Given this list of marker genes ABO, GATAD1, CXCR4, HBBP1, TRIP10, ERVW-1, SEMA7A, LPAR4, KIF25-AS1, SERPING1, INA, ALOX15B, SEMA4D, PRPF3, OBSL1, STAR, MPZL1, RALGAPB, MAG, AK1, APOL1, CECR7, CHAF1B, DEFB1, ST3GAL1, SAT1, TNFAIP3, KLF7, CYB5A, PITPNM1, USP20, CCNA2, FAM110B, KALRN, LBP, STX11 (syntaxin 11), CP, TUBB2A, RRH, KCNJ10, PPBP, XCL1, ZPR1, DUSP4, HARS2, SEMG2, DRD1, RARRES1, RGS1, GALNT2, MATN1, CASK, FAM153A, RAB40A, AGRN, CDK5R2, ZSCAN9, SLC24A5, IL15RA, MAP2K1, KIFC1, ANP32E, NRP2, TNFAIP2, GADD45B, FANCI, POLA2, NR4A3, SFTPC, AURKB, PKN2, TRA2A, RELB, FOXN3, SIKE1, TAP1, EFNA3, CAMK2B, LY75, BASP1, CEBPD, NFKBIA, PAIP2B, AK4, ALAS2, IFI6, SIAH1, ZBTB5, TUBB4A, NTRK1, GGH, NUP62, PEX12, ZFR2, CCR7, CRYGA (NCBI Gene Id 1418), DUSP1, HNRNPL, RPRD2, HEXIM1, SOD2, CFLAR, TRAF5, PTPRT, ICAM4, FASLG, MATN2, RAPGEF2, PDK2, RSAD2, AATK, DEPP1, NCK2 (NCK adaptor protein 2), AFF2, DCT, B4GALNT1, GP2, HNRNPF, BNIP3L, IGKC, KDM6A, NFKB1, ISG20, NFKB2, GNA12, IFIT3, MGLL, RIPOR2, IL7R, PSME2, LAMP3, GP1BA, DUSP5, CD200, TAGLN2, CYP2C9, RUVBL1, FICD, TRAF1, MYH6, PNRC1, GAL, DIRAS3, FAM161A, ALDH3B2, COL4A2 (collagen type IV alpha 2 chain), CDK9, P2RY10, MYRF, CXCL9, BCAT1, PTPRK, IFRD1, POU6F1, EXT2, PENK, GNB5, NMU (NCBI Gene Id 10874), NOS1, WTAP, GATA1, CSF2RB, IFI35, H6PD, ACTC1, GBP1, SOCS3, TIMM44, ATP5MC2, TRIB1, EIF1AX, PSMA6, N4BP2L1 (NEDD4 binding protein 2 like 1), KRTAP26-1, IL13RA1, COL16A1, IMPA1, MPZL2, SLC12A3, OLIG2, SLC1A2, DGKB, SYN1, PPP1R16B, RCVRN, IFITM3, TMEM109 (NCBI Gene Id 79073), ADRB2, BTG1, KLF11, PTGER4, HMGCS2, PGAP4, TGM3, CD83, BTG3, SEC24A, SNTB1, here is a description of the gene set: species: Homo sapiens Human Gene Set: GSE360_CTRL_VS_T_GONDII_DC_DN from publication Chaussabel D, Semnani RT, McDowell MA, Sacks D, Sher A, Nutman TB (PMID 12663451) Genes down-regulated in untreated dendritic cells (DC) versus DCs exposed to parasite Toxoplasma gondii. Monocyte-derived dendritic cells (DC) and macrophages (MΦ) generated in vitro from the same individual blood donors were exposed to five different pathogens, and gene expression profiles were assessed by microarray analysis. Responses to Mycobacterium tuberculosis and to phylogenetically distinct protozoan (Leishmania major, L. donovani, Toxoplasma gondii) and helminth (Brugia malayi) parasites were examined, each of which produces chronic infections in humans yet vary considerably in the nature of the immune responses they trigger.